Given this list of marker genes RCOR3, PPP1R8, ASF1A, DDX31, IL13RA1, MNAT1, CSE1L, NOL3, MAP3K13, KCND1, NUP155, FSTL1, TNFSF12 (TNF superfamily member 12), MUTYH, H2BC9, NPFF, LPAR2, PRPS1, TMEM87A, SMARCA4 (SWI/SNF related, matrix associated, actin dependent regulator of chromatin, subfamily a, member 4), NVL (NCBI Gene Id 4931), SIGLEC1, SEC14L1, CHAT, MOCOS, SLC66A3, GRM5, POLM, MSL2, PREP, SLC1A4, SELPLG, CREB5, NSUN3, WWP2, SPINT2, CKAP5, STK38, GRSF1, GSE1, GOT2, C2CD3, INTS7, ABCB11, CTC1, ABCB7, NELL2, PRR5L, SPG7, SFRP4, HARS1, SHQ1, CARD8, EPM2A, LEPROTL1, DDX24, PRKAR2B, PAAF1, B3GALT4, AGK, TBC1D13, PGRMC2, GMPS, ACACB (acetyl-CoA carboxylase beta), RPF1, LRRC3, CYB5A, SETDB1, UTP14C, CEP41, SMG1 (NCBI Gene Id 23049), PDS5B, ABCC10 (NCBI Gene Id 89845), CEP63, NUP133, ANKRD49, SPRR2C, CLN8, VCL, ZC3H14, PCDHA2, PTCD1, TSR3, ZNF343, EIPR1, SLC35D1, NKG7, THBS3, MRPL57, HSPD1, GIMAP4, AP5S1, MTCL1, DCAF8, SEC16A, DARS1 (aspartyl-tRNA synthetase 1), CASS4, MEA1, PARP4, CCNH, PTGES, RESF1, ALDOAP2, LORICRIN, HOXA1, LPIN1, GPATCH8, SCN7A, RASSF2, GPR107, DCSTAMP, CCL19, INTS3, EOLA2, GNE, FOXO1, SIPA1L3, SARS2, ZNF16, MDC1 (mediator of DNA damage checkpoint 1), LIMD2, ZDHHC13, POLG2, OR7E24 (NCBI Gene Id 26648), THAP7, NAGPA, PIAS3, ARHGAP15, NDRG1, MAPK8IP3, FILIP1L, ARHGEF18, NUP88, TRAF5, CEBPG, MAT2A, KRT8P12, H2BC5, ALG12, UTP14A, SYF2, AMZ2 (archaelysin family metallopeptidase 2), PLCB1, CFP, ENPP1 (ectonucleotide pyrophosphatase/phosphodiesterase 1), DPH5, IFITM1, LILRA3, ARHGAP45, MT2A, BAZ1B, POLD3, RECQL5, CCDC69, TAF5L, ARL4C, ZNF695, ZKSCAN5, DNAJC16, CIRBP, MFAP1, LETMD1, CDC23, PDE4A, TARS1, IMP3, MGA, FAM136A, C6orf15, ZNF248, MTMR4, GTF2E1, GSTP1, FNBP4, PLAU, ADGRG2 (adhesion G protein-coupled receptor G2), IRF4, CBR3, AQP3, NDUFV2, SMURF1, GNPDA1, ZDHHC18, KMT5B, PSMD6 (proteasome 26S subunit, non-ATPase 6), TACSTD2 (NCBI Gene Id 4070), XPO4, YLPM1, CIZ1, DNAI1, E2F6, PRR7, ABCC3, NME3, OGT, SHC1, TERF2IP, FOSB, TRMO, RANGRF, here is a description of the gene set: Human Gene Set: GSE3982_DC_VS_MAC_LPS_STIM_UP species: Homo sapiens Genes up-regulated in comparison of dendritic cells (DC) stimulatd with LPS (TLR4 agonist) at 48 h versus macrophages stimulated with LPS (TLR4 agonist) at 4 h. In the present study we used Affymetrix oligonucleotide microarrays to produce gene transcription profiles for the major leukocyte types in humans. This comprehensive dataset enabled us to not only establish which genes were expressed in each leukocyte type, but also which genes were expressed in each subset after activation. The used of a comprehensive dataset of gene profiles from all the major human leukocyte subsets enabled a novel and powerful means for identification of genes associated with single leukocyte subsets, or different immune paradigms. from publication Jeffrey KL, Brummer T, Rolph MS, Liu SM, Callejas NA, Grumont RJ, Gillieron C, Mackay F, Grey S, Camps M, Rommel C, Gerondakis SD, Mackay CR (PMID 16474395)